The following is a description of a gene set: Human Gene Set: WP_INHIBITION_OF_EXOSOME_BIOGENESIS_AND_SECRETION_BY_MANUMYCIN_A_IN_CRPC_CELLS Inhibition of exosome biogenesis and secretion by manumycin A in CRPC cells species: Homo sapiens, and this is the list of marker genes: RAB27A, RAB5A (RAB5A, member RAS oncogene family), RRAS, MRAS, HRAS, ARAF, BRAF, RAB5B, PDCD6IP, MAPK1, MAPK3, KRAS, RAF1, HNRNPH1, NRAS, HGS, RRAS2, RAB5C